Given this list of marker genes Slc17a8, Ddc, Slc17a6, Slc17a7, Slc18a1, Slc32a1, Th, Slc18a3, Slc18a2, Slc10a4, Slc17a5, here is a description of the gene set: species: Mus musculus Mouse Gene Set: GOBP_NEUROTRANSMITTER_LOADING_INTO_SYNAPTIC_VESICLE The active transport of neurotransmitters into a synaptic vesicle. This import is fuelled by an electrochemical gradient across the vesicle membrane, established by the action of proton pumps.